The following is a description of a gene set: Naturally arising CD25+CD4+ regulatory T cells (T(R) cells) are engaged in the maintenance of immunological self-tolerance and immune homeostasis by suppressing aberrant or excessive immune responses, such as autoimmune disease and allergy. T(R) cells specifically express the transcription factor Foxp3, a key regulator of T(R)-cell development and function. Ectopic expression of Foxp3 in conventional T cells is indeed sufficient to confer suppressive activity, repress the production of cytokines such as interleukin-2 (IL-2) and interferon-gamma (IFN-gamma), and upregulate T(R)-cell-associated molecules such as CD25, cytotoxic T-lymphocyte-associated antigen-4, and glucocorticoid-induced TNF-receptor-family-related protein. However, the method by which Foxp3 controls these molecular events has yet to be explained. Here we show that the transcription factor AML1 (acute myeloid leukaemia 1)/Runx1 (Runt-related transcription factor 1), which is crucially required for normal haematopoiesis including thymic T-cell development, activates IL-2 and IFN-gamma gene expression in conventional CD4+ T cells through binding to their respective promoters. In natural T(R) cells, Foxp3 interacts physically with AML1. Several lines of evidence support a model in which the interaction suppresses IL-2 and IFN-gamma production, upregulates T(R)-cell-associated molecules, and exerts suppressive activity. This transcriptional control of T(R)-cell function by an interaction between Foxp3 and AML1 can be exploited to control physiological and pathological T-cell-mediated immune responses. Genes down-regulated in CD4+ T lymphocytes by expression of AML1 off a viral vector. Human Gene Set: ONO_AML1_TARGETS_DN from publication Ono M, Yaguchi H, Ohkura N, Kitabayashi I, Nagamura Y, Nomura T, Miyachi Y, Tsukada T, Sakaguchi S (PMID 17377532) species: Mus musculus, and this is the list of marker genes: FFAR2, GPR83, IL21, IL4R, IZUMO1R, CCR8, RUNX2, IGFBP4, CCR7, CCL5, SELL, TCF3, SGO1, ITGAE, CD81, IL10, IL17A, RBL1, ADGRE5, PARP1, CDK6, CD84, SLAMF6, CXCR3, CCR5, TNFSF8, CREM, TNFRSF18, CASP4 (NCBI Gene Id 837), CXCR4, RUNX3, SOCS3, CCR2, TNFRSF25, IL4, FOXN3, IL17RA, IRF4, SOCS2 (NCBI Gene Id 8835, suppressor of cytokine signaling 2), SLFN12